The following is a description of a gene set: Type 1 IFNs can conditionally activate all of the signal transducers and activators of transcription molecules (STATs), including STAT4. The best-characterized signaling pathways use STAT1, however, and type 1 IFN inhibition of cell proliferation is STAT1 dependent. We report that type 1 IFNs can basally stimulate STAT1- and STAT4- dependent effects in CD8 T cells, but that CD8 T cells responding to infections of mice with lymphocytic choriomenigitis virus have elevated STAT4 and lower STAT1 expression with significant consequences for modifying the effects of type 1 IFN exposure. The phenotype was associated with preferential type 1 IFN activation of STAT4 as compared to STAT1. Stimulation through the TCR induced elevated STAT4 expression, and STAT4 was required for peak expansion of antigen-specific CD8 T cells, low STAT1 levels, and resistance to type 1 IFN-mediated inhibition of proliferation. Thus, a mechanism is discovered for regulating the consequences of type 1 IFN exposure in CD8 T cells, with STAT4 acting as a key molecule in driving optimal antigen-specific responses and overcoming STAT1-dependent inhibition of proliferation. from publication Gil MP, Ploquin MJ, Watford WT, Lee SH, Kim K, Wang X, Kanno Y, O'Shea JJ, Biron CA (PMID 22968462) Genes down-regulated in CD8 T cells treated by interferon alpha: STAT1 knockout versus STAT4. Human Gene Set: GSE40666_STAT1_KO_VS_STAT4_KO_CD8_TCELL_WITH_IFNA_STIM_90MIN_DN studied in species Homo sapiens, and this is the list of marker genes: CXCL2, CXCL8, HBM, DIRAS2, VAX2, DUSP2, ADGRB2, BTG2 (NCBI Gene Id 7832, BTG anti-proliferation factor 2), LINGO3, UBE2H, FAM83A, FAM167A-AS1, CFLAR-AS1 (CFLAR antisense RNA 1), MIR924HG, PCP2, NMNAT3, ATP1A3, C11orf97, C1orf35, JUN, WTIP, PCDHB11, F3, ZNF652, GATA6, MYOCD, PPP1R15A, CPLX1, ST3GAL3, CSRNP1, TSC22D1-AS1, NKX1-1, CADPS2, EGR1, VN1R4, FAM149A (family with sequence similarity 149 member A), PPP1R8, CHRNB2, SOCS3, ROS1, TMEM88, NR4A2, KCNQ4, F7, SOX21, INSIG1, EXTL3, GPR183, AQP10, GKN1, SNHG10, VEGFA, NFE2, DHH, CROCCP2, CFAP52, MIR124-1HG, PJA2, DIPK1B, TCP11L2, ZNF467, POU2AF2, IER3, ADAMTSL5, METTL21C, SELENOK, HMHB1, ZDHHC14, CIB3, HTR1B, UBE2W, SH3GL1P2, CCK, MAP2K3 (mitogen-activated protein kinase kinase 3), TAMALIN, SLC25A3P1, CDH20, TBC1D28, PPY2P, LINC01854, ENTPD2, EGR3, OSM, ZNF24, COX6C, LY6E-DT, PCDHGB8P, NR2F2-AS1, ATG12, KRT13, NTN5 (netrin 5), DSCAM-AS1, TAX1BP1, CPXM1, PLPP2 (NCBI Gene Id 8612), CEP104, PLVAP, CASZ1, ACACB (acetyl-CoA carboxylase beta), TRO (trophinin), DEFB124, TRIM15, ADCY5, C4BPA, CD177, FZD1, SUCNR1, LINC02907, NOXO1, LRRC36, POLN, SOX18, LINC00161, UBE2QL1, OPTC, SPTBN1, NDEL1, TSHB, ZNF831, TEX29 (testis expressed 29), OTUD7A, IGHMBP2, LRP6, KLK4, PAGE1, ANGPTL4, DOC2A, ELOA3P, KPNB1, GUCA1B, SPAG11B, VWA1, TNFRSF14-AS1, LINC02593, NR4A3, ABO, DBH, SNORA78 (NCBI Gene Id 677844), CDC42SE1, CCL4, EZHIP, EGR2, TNF, SNORA68, SLC2A3, NR4A1, SPMAP1, CRCP, HIF1A, FOSB, SSTR2, ARL8A, SARAF, PIWIL2, PTGIR, CPNE8, RANBP9, PIM3, BHLHE40, HBEGF, CASKIN1, SLC29A2, ENAH, RSPH4A, GJA4, RBP5, PLAU, NTN3, TIPARP, KBTBD8, DCUN1D1, SH2D1A, LOXL4, KCNN3, MROH2A, KIF12, HABP2, CACNA1B, CERS4, BMS1P2, ALOX12B, LAG3, CDK5R2, KIAA1614